The following is a description of a gene set: Mouse Gene Set: GOBP_RHO_PROTEIN_SIGNAL_TRANSDUCTION species: Mus musculus An intracellular signaling cassette in which a small monomeric GTPase of the Rho subfamily relays a signal., and this is the list of marker genes: Adra1a, Cnksr1, Stmn1, Dock11, Pdpn, Apoc3, Apoa1, Lrrk2, Arhgef12, Arrb1, Ctnnal1, F2rl1, Cdc42ep2, Eps8l1 (EPS8-like 1), Rock2, Kank1, Plekhg5, Abca1 (ATP-binding cassette, sub-family A member 1), Ednra, Itgb1, Fermt2, Plxnb1, Myoc, Phactr4, Synj2bp, Ccdc125, Cdc42ep5 (NCBI Gene Id 97398), 4930544G11Rik, Lpar2, Gna13, Rtkn, Racgap1, Srgap1, Eps8l3, Arhgef3, Vangl2, Akap13, Arhgef2 (Rho/Rac guanine nucleotide exchange factor 2), Ralbp1, Dock7, Itga3, Hacd3, Rock1, Ophn1, Cdc42se1 (NCBI Gene Id 99930), Rit2, Nradd, Abra, Gpr4, Nfix, Dock6, Cavin4, Arhgap27, Myo9b, Flcn, Rasip1, Kctd13, Stard8, Was, Cdh2, Arhgap35, Dock10, Arhgdig, Ntn1 (netrin 1), Arhgap5, Heg1, Pdgfrb, Mcf2l (mcf.2 transforming sequence-like), Scai, Dock8, Arhgap32, Adrb1, Cdc42ep3, Cdc42se2, Eps8l2, Shtn1, Stard13, Sema4d, Cdc42ep1, Rhoj, Tns3, Ngfr, Arhgef28, Prag1, Bcr, Pth, Csnk1a1, Col1a2, Arhgap20, Adra1b, F11r, Eps8, Celsr1, Agtr1b, Fxr1, Rtn4r, Met, Net1, Agtr1a, Ripor1, Dock9, Gm14137, Abl2, Arhgef11, Cdc42, Arhgef7, Arhgdib, Flot1, Abl1 (c-abl oncogene 1, non-receptor tyrosine kinase), Kank2, Tnfaip1, Adgrg1, Robo1 (NCBI Gene Id 436378), Apoe, Col3a1, Ripor2, Cdc42ep4 (NCBI Gene Id 72009), Arhgap42, Bcl6, Baiap2 (brain-specific angiogenesis inhibitor 1-associated protein 2), Rhoa (ras homolog family member A), Arhgef18, Synpo2l, Pecam1, Tagap, Tax1bp3, Rhog (NCBI Gene Id 72751), Gna12, F2r, Lpar1, Dlc1, Nrp1, Erbb2, Cdh13, Gpr55, Kctd10, Cul3, Arhgdia